Given this list of marker genes CLN3, TIFAB, LETM1, PTGS2, ARHGEF2, YBX3, EPO, EFHD1, MLC1, USP15 (ubiquitin specific peptidase 15), BAD, SLC25A23, TRPV4, BDKRB2, MICU1, here is a description of the gene set: Any process that modulates the rate or extent of the response to osmotic stress. Human Gene Set: GOBP_REGULATION_OF_RESPONSE_TO_OSMOTIC_STRESS studied in species Homo sapiens